Given this list of marker genes Tnfsf4, Cracr2a, Socs5 (suppressor of cytokine signaling 5), Hmgb1, Il18r1, Tbx21, Ccr2, Ripk2, Il1r1, Arid5a, Il12b, Jak3, Hras, Spn, Pla2g4a, Irf1, Relb, Traf6, Il18 (interleukin 18), Mtor, Il12a, Hlx (NCBI Gene Id 15284), Xcl1, Anxa1, Slc11a1, Gadd45g, Il27, Il18rap, Lef1, Havcr2, Il23r, Slamf1, Ccr7, Il1rl1, Il27ra, Bcl3, Il1b, Il4, Il4ra, Stat6, Nfkbiz, Il33, Il18bp, Il23a, Sema4a, Ascl2, Vegfa, Stat4, Ccl19, Tmem98, Nlrp10, Il12rb1, here is a description of the gene set: species: Mus musculus Mouse Gene Set: GOBP_T_HELPER_1_TYPE_IMMUNE_RESPONSE An immune response which is associated with resistance to intracellular bacteria, fungi, and protozoa, and pathological conditions such as arthritis, and which is typically orchestrated by the production of particular cytokines by T-helper 1 cells, most notably interferon-gamma, IL-2, and lymphotoxin.